The following is a description of a gene set: from publication Howe DG, Blake JA, Bradford YM, Bult CJ, Calvi BR, Engel SR, Kadin JA, Kaufman TC, Kishore R, Laulederkind SJF, Lewis SE, Moxon SAT, Richardson JE, Smith C (PMID 30224793) species: Mus musculus Mouse genes annotated to HALLMARK_ADIPOGENESIS based on orthology mappings provided by the Alliance Genome Consortium Mouse Gene Set: HALLMARK_ADIPOGENESIS, and this is the list of marker genes: Uqcr10, Gpx4, Rmdn3, Scarb1, Gadd45a, Gpx3, Ywhag, Idh3a, Sncg, Cd151, Cavin1, Retn, Acadm, Pfkfb3, Mylk, Slc19a1, Dgat1, Sorbs1, Rreb1, Hadh, Me1, Agpat3, Araf, Dlat, Scp2, Slc25a10, Esyt1, Orm1, Slc5a6, Phldb1, Rab34, Sparcl1, Cidea, Ppm1b, Angptl4, Mdh2, Cox7b, Ucp2, Uqcrc1, C3, Sqor, Tkt (NCBI Gene Id 21881), Fzd4, Elmod3, Itih5, Adcy6, Aldh2, Uqcr11, Sowahc (NCBI Gene Id 70860), Ppp1r15b, Riok3, Gpat4, Acads, Fah, Pparg, Mccc1, Coq9, Arl4a, Gbe1, Cmpk1, Rnf11, Angpt1, Tank, Cox6a1, Gphn, Dnajb9, Ak2, Lpl, Sdhc (succinate dehydrogenase complex, subunit C, integral membrane protein), Nmt1, Adipoq, Pgm1, Crat, Rtn3, Lep, Cmbl, Nabp1 (nucleic acid binding protein 1), Ddt, Pim3, Prdx3, Enpp2, Decr1, Elovl6, Acadl, Col15a1, Ptcd3, Itsn1, Atl2, Baz2a, Acox1, Dhcr7, Lifr, Atp1b3, Ubc, Etfb, Cox8a, Taldo1, Cdkn2c, Fabp4, Ndufb7, Sdhb, Coq5, G3bp2, Apoe, Dnajc15, Cat, Nkiras1, Samm50, Mrpl15, Pex14, Ptger3 (prostaglandin E receptor 3 (subtype EP3)), Gpd2, Ltc4s (NCBI Gene Id 17001), Pemt, Abca1, Ephx2, Abcb8, Qdpr, Mtarc2, Mgst3, Tob1, Mrap, Uqcrq, Cyc1, Stom, Por, Immt, Slc1a5, Ech1, Reep5, Cavin2, Hspb8, Aco2 (aconitase 2, mitochondrial), Plin2, Ghitm, Reep6, Sod1, Pdcd4, Acaa2, Adipor2, Itga7, Acly (NCBI Gene Id 319932), Grpel1, Dbt, Mtch2, Ccng2, Cpt2, Map4k3, Hibch, Atp5po, Ifngr1, Mgll, Lipe, Cs, Retsat, Cd36, Miga2, Stat5a, Ndufab1, Gpam (NCBI Gene Id 14732), Idh3g, Chchd10 (NCBI Gene Id 216112), Slc27a1, Chuk, Sult1a1, Col4a1, Esrra, Phyh, Bcl6, Ndufa5, Lpcat3, Dhrs7b, Sspn, Bcl2l13, Suclg1, Cd302, Ndufs3, Slc66a3, Bckdha, Ubqln1, Coq3, Dld, Preb, Pfkl, Echs1, Dhrs7, Adig, Jagn1, Aldoa (NCBI Gene Id 11674), Omd, Vegfb, Aplp2, Aifm1 (NCBI Gene Id 26926), Slc25a1 (NCBI Gene Id 76777), Dram2, Tst (NCBI Gene Id 22117), Cyp4b1, Uck1, Lama4, Idh1